Given this list of marker genes TMEM51, PSG4, FA2H, FOSL1, DDX39A, TRPV6, TLR3, INAVA, PITPNA, KATNBL1, PRSS8, AHSG, DGAT1, NFYA, AUNIP, ALB, APOH, NCK2, NSUN5, IDH3G, HSD17B14, LILRA4, LIPG, BZW1, BARX2, MAGEB3, HBE1, VKORC1, FBN2, TCN2, EXT1, GP9 (NCBI Gene Id 2815, glycoprotein IX platelet), PRTN3, PEA15, NINJ2, DOC2A, PCID2, LAMA5, PLEKHF1, P2RY14, PRR7, CYLC1, DCSTAMP, EXTL1, CDC23, TMEM30B, ENO1, CERNA1, MON1B, ESR1, PSMD11, RTF2, TEKT2, CEBPD, HBEGF, TEK, BNC1, WASF3, PPIH, TSPAN15, KCNC4, NEU1, SAMD4A, SERPINA4, PAIP1, MIR22HG, RANGRF, PRSS2, CDC27, CSTF1, CDK5R1, SLC2A1, MYLK, SEMG1, TVP23B, KLHL1, TMCO1, ANGPTL8, RAD1, CLN3, CD247, UFD1, DHCR7, ADGRL4, OSBPL7 (oxysterol binding protein like 7), MAPK13, TEF, GIMAP5, C1GALT1C1, UGGT1, THRAP3, HOXB3, HSPA9, FAM8A1, SLC5A4, IL6R, ARMC1, NOVA2, ACTR6, ETFDH, NUDT6, NAA38, RMDN3, CSF1R, ARF3, CPNE6, ELL, RAB33B, ZBTB16, BRIX1, HOXB6, TBC1D31, XRCC2, SERPING1, H3-3B, DPF3, NELFCD, CD2, PYGO1, MMRN2, SLC22A4, SLC9A1, MTMR11, CD40LG, APOL1, IMP3, SLCO3A1, CASP1, RNF126, KLRG1, C1QL1, SNRNP40, GUCY1A2, TFE3, SH2D1A, CACNA1H, ROBO1 (NCBI Gene Id 6091), GLRX (NCBI Gene Id 90885), INTS11, MYBPC1, DPPA4, FLT4, CXCR6, YES1, AATF, MYDGF, CDCA3, CREB3L2, ULBP2, SIGMAR1, FSD1, HSPA5, NTRK2, MTNR1B, URM1, P3H2, ADAM30, FUT8, DUSP6, SERPINE1, CRIM1, HOPX, ACTL7A (NCBI Gene Id 138761), DOP1A, PDZD2, ZBBX, CRYL1, CD59, IFT57, RPH3AL, GORASP2, NGB (NCBI Gene Id 731373), ITFG1, COPE, KRT75 (keratin 75), TDO2, HSPA1A, C15orf39, ZNF205, DDX31, MICA, NDNF, BMAL1, PADI1, PLCB1, AFF4, TENM1, PTH2R, ATAD2, MRPL49, CXCL2, MKNK1, MST1R, CNPY4, WSB2, here is a description of the gene set: species: Homo sapiens Genes up-regulated in hematopoietic stem cells versus common lymphoid progenitors. from publication Ramirez K, Chandler KJ, Spaulding C, Zandi S, Sigvardsson M, Graves BJ, Kee BL (PMID 22608498) Expression profiling of Rag2-deficient Ets1++ and Rag2-deficient Ets1-- mature NK cells and WT bone marrow progenitors, WT T cells, and WT Pro B cells Human Gene Set: GSE37301_HEMATOPOIETIC_STEM_CELL_VS_COMMON_LYMPHOID_PROGENITOR_UP